Given this list of marker genes FAN1, KAT2B, GRM6, GOLGA8R, FYN, TRPM1, CHRFAM7A, OTUD7A, ULK4P1, FANCD2, CHRNA7, ARHGAP11B, MIR211, CCL5, GPR75, KLF13, CREBBP, ULK4P2 (ULK4 pseudogene 2), SERPINH1, GOLGA8H, GOLGA8Q, MTMR10, GOLGA8O, here is a description of the gene set: studied in species Homo sapiens Human Gene Set: WP_15Q133_COPY_NUMBER_VARIATION_SYNDROME 15q13.3 copy number variation syndrome